Given this list of marker genes Cldn16, Cldn15, Cldn17, Cldn19, Cldn10, Cldn2, here is a description of the gene set: Enables size- and charge-selective transport of solutes through a tight junction barrier paracellularly, across the epithelium. Mouse Gene Set: GOMF_PARACELLULAR_TIGHT_JUNCTION_CHANNEL_ACTIVITY species: Mus musculus